The following is a description of a gene set: Human Gene Set: LI_ESTROGENE_EARLY_E2_RESPONSE_UP from publication Li Z, Li T, Yates ME, Wu Y, Ferber A, Chen L, Brown DD, Carroll JS, Sikora MJ, Tseng GC, Oesterreich S, Lee AV (PMID 37272757) studied in species Homo sapiens High confident estrogen up-regulated genes in early treatment duration (≤6 hours) in breast cancer cells merged from 58 NGS datasets-based comparisons (10% topmost up-regulated genes and consistent in at least 50% comparisons). As one of the most successful cancer therapeutic targets, estrogen receptor-alpha (ER/ESR1) has been extensively studied over the past few decades. Sequencing technological advances have enabled genome-wide analysis of ER action. However, comparison of individual studies is limited by different experimental designs, and few meta-analyses are available. Here, by ingesting large amount of E2-related transcriptomic data sets in breast cancer cell lines, we identified gene expression changes across 66 RNA-seq and 80 microarray experiments based upon the E2-induced fold change in gene expression. Among the 146 merged transcriptomic datasets, 27 different time points were annotated spanning from 5 minutes to 600 hours of estrogen stimulation. We separated all the comparisons into three signatures of duration: EstroGene_Early (≤6 hours, n = 58), EstroGene_Mid (6-24 hours, n = 44) and EstroGene_Late (≥ 24 hours, n = 44). Upregulated and downregulated genes present in the top 10th percentile of regulated genes in each individual study, and consistently present across at least 50% of studies at each time period, were extracted from each signature (early, mid, and late) and intersected accordingly. We identified 165, 59 and genes representing early, mid, and late estrogen response signatures, respectively., and this is the list of marker genes: PXK, MANEAL, MYBL1, RAPGEFL1, ZNF703, IGFBP4, FOS, RBM24, MREG, HEY2, JAK2, DDX10, RBP7, PRAG1, USP31, SLC7A5, CCND1, SLC22A5, RASGRP1, SFXN2, CXXC5, ELOVL2, PFKFB3, RAB31, HSPB8, SGK1, CA12, FCMR, WWC1, FMN1 (NCBI Gene Id 649014), ADORA1, NPY1R, HCK, SGK3, PLIN5 (NCBI Gene Id 440503), TIPARP, FOXC1, IL17RB, SLC47A1 (NCBI Gene Id 55244), STC2, NEIL2, SEC14L2, SYBU, KCNK5, CXCL12, MBOAT1, RET, NHERF1, NR5A2, FKBP4, THBS1, PMAIP1, MYC, OSGIN1, KCNK6, PPIF, DEPTOR, SLITRK4, CISH, MYB, EEIG1, CASTOR1, NKAIN1, MICB, KRT13, ADCY9, CCDC88C, FHL2, C1orf226, ADRB1, NRIP1, ASB13, TMPRSS3, CELSR2, TPD52L1, RARA, NOP16, DOK7 (NCBI Gene Id 619409), AMZ1, EGR3, PKIB, PTGES, GREB1, SIAH2, PGR, PDZK1, LONRF2, SEMA3G